Given this list of marker genes Atp10a, Atp8b2, Abcb1b, Abcb4, Abcb1a, Abca7, Abcg1, Abca1, Atp8b1, here is a description of the gene set: Catalysis of the movement of phosphatidylcholine from the cytosolic to the exoplasmic leaflet of a membrane, using energy from the hydrolysis of ATP. Mouse Gene Set: GOMF_PHOSPHATIDYLCHOLINE_FLOPPASE_ACTIVITY species: Mus musculus